Given this list of marker genes SYK, MIF, PLA2G10, AVPR1B (arginine vasopressin receptor 1B), PLA2R1, NTSR1, here is a description of the gene set: Human Gene Set: GOBP_REGULATION_OF_ARACHIDONATE_SECRETION Any process that modulates the rate, frequency, or extent of arachidonic acid secretion, the controlled release of arachidonic acid from a cell or a tissue. species: Homo sapiens